The following is a description of a gene set: studied in species Mus musculus from publication Chiaradonna F, Sacco E, Manzoni R, Giorgio M, Vanoni M, Alberghina L (PMID 16607279) Mutational activation of ras genes is required for the onset and maintenance of different malignancies. Here we show, using a combination of molecular physiology, nutritional perturbations and transcriptional profiling, that full penetrance of phenotypes related to oncogenic Ras activation, including the shift of carbon metabolism towards fermentation and upregulation of key cell cycle regulators, is dependent upon glucose availability. These responses are induced by Ras activation, being specifically reverted by downregulation of the Ras pathway obtained through the expression of a dominant-negative Ras-specific guanine nucleotide exchange protein. Our data allow to link directly to ras activation the alteration in energy metabolism of cancer cells, their fragility towards glucose shortage and ensuing apoptotic death. Human Gene Set: CHIARADONNA_NEOPLASTIC_TRANSFORMATION_CDC25_DN Genes down-regulated in reverted NIH3T3 cells (fibroblasts transformed by activated KRAS which then reverted to normal cells upon stable over-expression of a dominant negative form of CDC25) vs normal fibroblasts., and this is the list of marker genes: SERPINB6, AGRN, GAMT, AQP1, SNAPC2 (NCBI Gene Id 6618), ABHD8 (NCBI Gene Id 79575), ACOT7, ASNS, LYPLA1, GAS7, SEMA3F, DAP, PNPLA2, MYO1C, GALK1, S100A1, NFIC, TNS2, GPC1, RNASE4, UTRN, BHLHE40, LASP1, TUBA8, ICA1, SRI, AVPI1, ABCC1, DGCR6, RNF13, ADRA2B, H2BC4, CSRP1 (NCBI Gene Id 1465), CD9, TALDO1, PAPSS2, TM2D2, CYB5B, S100A13, RETREG1, BAG2, SKAP2, CYP51A1, TNXB, DBNDD2, PNKD, TIMP3, TEAD4, LDAF1, WWP2, ITGB4, ASAH1, GIPC1 (NCBI Gene Id 10755), IGFBP4, SLC1A5, TRAM1 (NCBI Gene Id 23471), CYB5R1, BAIAP2, SLC35E4, GSTM5, PLIN2, TSPO, NMT1, RFLNB, PKP2, MGST3, TRAK1, DDR2, NFE2L1, SEC14L1, CARHSP1, MAP6, RNPEPL1, KLF2, ARHGEF2, STAT6, NUPR1, TMEM45A, TMBIM1, NAA38, COL4A1, CSNK2A1, VPS26C, MSLN, CAPG, PLTP, LAMC2, ADRB2, ELN, MEA1, POLD4, TRIM47, MAP1LC3B, EBF3, DAB2, COL4A2, FHL1, SNX10, BBLN, KLK8, RHOA, ALDH2, KLF4, SEMA3C, CLIC1, SLC66A3, DUSP1, FHL2, FBN1, NRBP2, ANXA4, NPPB, CLEC3B, GUK1, EMP3, FZD2, CD34, CARD19, C16orf89, PHLDA3, CES2, ADM, AKAP12, ACP2, NEDD9, PRSS23, CCN2, LGALS9, RBMS2, EIF4EBP1, IFI30, PLAC8, TRIB3, SLC29A1, FXYD5, ATP6V0B, MYZAP, TMEM43, TOB1, PLEKHA7, CD151, ERO1A, ENO3, QKI, NDRG4, ANXA8L1, CLIC4 (NCBI Gene Id 25932), ACYP2, DIPK2A, VAMP5, COL5A2, ANXA11